The following is a description of a gene set: Cytokines mediate cell-cell communication in the immune system and represent important therapeutic targets. A myriad of studies have highlighted their central role in immune function, yet we lack a global view of the cellular responses of each immune cell type to each cytokine. To address this gap, the authors created the Immune Dictionary, a compendium of single-cell transcriptomic profiles of more than 17 immune cell types in response to each of 86 cytokines (>1,400 cytokine-cell type combinations) in mouse lymph nodes in vivo. A cytokine-centric view of the dictionary revealed that most cytokines induce highly cell-type-specific responses. For example, the inflammatory cytokine interleukin-1β induces distinct gene programmes in almost every cell type. A cell-type-centric view of the dictionary identified more than 66 cytokine-driven cellular polarization states across immune cell types, including previously uncharacterized states such as an interleukin-18-induced polyfunctional natural killer cell state. from publication Cui A, Huang T, Li S, Ma A, Pérez JL, Sander C, Keskin DB, Wu CJ, Fraenkel E, Hacohen N (PMID 38057668) species: Mus musculus Mouse Gene Set: CUI_T_CELL_CD4_G_CSF_RESPONSE_DN Genes negatively differentially expressed in cell type: CD4+ T cell upon treatment with cytokine: G-CSF in mouse lymph nodes in vivo., and this is the list of marker genes: Cd74, Igkc, Hspa1a, Hspa8, Tsc22d3